The following is a description of a gene set: studied in species Mus musculus Mouse Gene Set: GOBP_REGULATION_OF_BLOOD_BRAIN_BARRIER_PERMEABILITY Any process that modulates blood-brain barrier permeability, the quality of the blood-brain barrier that allows for a controlled passage of substances (e.g. macromolecules, small molecules, ions) into and out of the brain., and this is the list of marker genes: Tjp2, Ocln, Abcc8, Ifnb1, Zeb2, Tjp3, Vegfa (vascular endothelial growth factor A), Angpt1, Sh3gl2, Tjp1